Given this list of marker genes PSMC3, RPL27A, PSMB6, RPL28, RPL32, NEMF, RPS27A, UFD1, UBE2D1 (ubiquitin conjugating enzyme E2 D1), RPL22, PSMC6, RPL10L, RPL17, PSMC4, PSMD13, PSMC2, RPL7, PSMB2, PSMD14, UBC, RBX1, PSMA2, RPL35A, RPL12, RPL37A, PSMA4 (proteasome 20S subunit alpha 4), PSMD7, ANKZF1, RPLP0 (ribosomal protein lateral stalk subunit P0), RPL18A, RPL11, RPL27, RPL15, RPL34, RPL9, CUL2, PSMB5, RPL37, ELOB, RPL29, PSMB1, PSMB7, RPL14, RPL31, RPL36A, PSMA7, KLHDC10, RPL3, TCF25, LTN1, PSMB4, RPL22L1, RPL39, RPL5, RPL4, RPL18, RPL3L, PSMD8, RPL13, UBA52, PSMA1, PSMD3, RPL7A, RPL30, UBB (NCBI Gene Id 91253), RPLP1, RPL19 (NCBI Gene Id 6143), RPL10A, RPL36AL, RPL13A, VCP (valosin containing protein), RPLP2, RPL36, ADRM1, RPL6, PSMD1, 5S rRNA, RPL8, RPL38, RPL26L1, RPL35, SEM1, PSMC1, RPL26, PSMD2, NPLOC4, PSMA5, PSMD6, 5.8S rRNA, PSMA6, PSMB3, RPL23A, ELOC, PSMC5, UBE2D2, PSMD12, RPL24, RPL21, RCHY1, RPL23 (ribosomal protein L23), PSMA3, RPL10, 28S rRNA, PSMD11, RPL39L, RPL41, here is a description of the gene set: part of: Ribosome-associated quality control species: Homo sapiens After the 80S ribosome is split into a 40S subunit and a 60S subunit that contains the peptidyl-tRNA at the P site, NEMF (the human homolog of yeast RQC2) binds the exposed peptidyl-tRNA of the isolated 60S ribosomal subunit produced by either the RQT complex or ABCE1 and transfers alanine residues from aminoacyl tRNAs to the C-terminus of the nascent peptide, a process termed Carboxy-terminal Alanine and Threonine tailing (CAT-tailing) after the alanine and threonine tails observed in yeast. Structures of CAT-tailing intermediates in yeast indicate that RQC2 positions an aminoacyl-tRNA in the A site of the 60S subunit and eIF5A enables peptidyl transfer.<br>The alanine C-terminal tails are believed to push the nascent peptide through the exit tunnel of the 60S ribosomal subunit to expose lysine residues for K48 ubiquitination by Listerin (LTN1), however alanine tails can cause aggregation of nascent peptides. The alanine tails can also act as degrons by binding the CRL2-KHDC10 ubiquitin E3 ligase complex or the RCHY1 (PIRH2) ubiquitin E3 ligase CRL2-KHDC10 and RCHY1 ubiquitinate the nascent peptide using K48 polyubiquitin linkages, targeting the nascent peptide for destruction by the 26S proteasome.<br>Listerin (LTN1, also called RKR1 in yeast), a ubiquitin E3 ligase, is also capable of K48 ubiquitinating the nascent peptide after NEMF recruits LTN1 to the 60S ribosomal subunit. The N-terminal region of LTN1 contacts the 60S ribosomal subunit and NEMF while the C-terminal region of LTN1 binds the 60S ribosomal subunit near the exit tunnel. TCF25 (the homolog of RQC1 in yeast) interacts with LTN1 (inferred from yeast homologs in Defenouillère et al. 2013).<br>LTN1 ubiquitinates exposed lysine residues on the nascent peptide after the residues have emerged from the exit tunnel of the 60S ribosomal subunit. TCF25, the human homolog of RQC1 in yeast, interacts with the RING domain of LTN1 to orient the ubiquitin substrate molecules to produce lysine-48 (K48) linkages in the polyubiquitin product.<br>A hexamer of VCP subunits plus a heterodimer of UFDL1 (UFD1) and NPLOC4 bind polyubiquitin that contains lysine-48 linkages (K48polyUb) and is conjugated to the nascent peptide emerging from the exit tunnel of the 60S ribosomal subunit. In yeast, the Npl4:Ufd1 heterodimer (homolog of NPLOC4:UFD1L) acts as an adapter that binds K48-linked polyubiquitin and inserts it into the pore of the VCP hexamer (inferred from rat p97 and Ufd1:Npl4 in Meyer et al. 2000, reviewed in Meyer and van den Boom 2023).<br>ANKZF1, which interacts with VCP, cleaves the C-terminal 3 nucleotides, CCA, of the tRNA in the peptidyl-tRNA bound to the 60S ribosomal subunit, yielding a free tRNA and the nascent peptide covalently bound to the CCA sequence. In yeast, Arb1 (mammalian ABCF2) occupies the E-site of the collided ribosome, extending a domain towards the peptidyl-tRNA that may help position it for release by Vms1/ANKZF1.<br>The VCP hexamer then extracts the ubiquitinated nascent peptide from the 60S ribosomal subunit. Six subunits of VCP surround the substrate protein, which is located in the central pore of the hexamer. Hydrolysis of ATP by a subunit causes it to disengage from the hexamer. Release of ADP and binding of ATP causes the subunit to rebind the hexamer more proximally to the 60S ribosomal subunit. The result is a ratcheting effect that withdraws the nascent peptide from the 60S subunit. The extracted nascent peptide remains bound to the ribosome-associated quality control complex (RQC complex, LTN1:NEMF:TCF25:VCP hexamer) which dissociates from the 60S ribosomal subunit and escorts the nascent peptide to the proteasome (inferred from yeast homologs in Defenouillère et al. 2017). The region of the nascent peptide that is unfolded by the VCP hexamer is able to enter the proteasome, resulting in degradation of the nascent peptide (inferred from the yeast homolog CDC48 in Olszewski et al. 2019). After removal of the ubiquitinated nascent peptide and tRNA, and mRNA, the 60S subunit is able to be re-used in translation. Reactome Pathway: Ribosome Quality Control (RQC) complex extracts and degrades nascent peptide